The following is a description of a gene set: studied in species Mus musculus Mouse Gene Set: GOMF_TYPE_3_METABOTROPIC_GLUTAMATE_RECEPTOR_BINDING Binding to a type 3 metabotropic glutamate receptor., and this is the list of marker genes: Calm2, Nherf1, Cabp1, Calm1, Calm3